The following is a description of a gene set: This event has been computationally inferred from an event that has been demonstrated in another species.<p>The inference is based on the homology mapping from PANTHER. Briefly, reactions for which all involved PhysicalEntities (in input, output and catalyst) have a mapped orthologue/paralogue (for complexes at least 75% of components must have a mapping) are inferred to the other species. Reactome Pathway: ERKs are inactivated studied in species Mus musculus part of: ERK/MAPK targets electronically inferred by orthology from the curated human pathway, and this is the list of marker genes: Ppp2r1b, Mapk3, Vrk3, Dusp6, Mapk7, Dusp7, Ppp2r5d